Given this list of marker genes IFITM5, KRT6A, KRT6B, KRT17, KRT16, here is a description of the gene set: studied in species Homo sapiens Human Gene Set: HP_HYPERPLASTIC_CALLUS_FORMATION Hyperplastic callus formation Increased growth of callus, the bony and cartilaginous material that forms a connecting bridge across a bone fracture during fracture healing.